The following is a description of a gene set: The process in which a transformation is induced in the topological structure of a double-stranded DNA helix, resulting in a change in linking number. species: Mus musculus Mouse Gene Set: GOBP_DNA_TOPOLOGICAL_CHANGE, and this is the list of marker genes: Top3a, Tdrd3, Hmgb2, Top1, Top3b, Top2b, Top1mt, Top2a, Ercc3